Given this list of marker genes NTRK2, GRIN3A, PIK3R2 (phosphoinositide-3-kinase regulatory subunit 2), PRKAG2, GRM1, PRKAB1, TSC2, PIK3CD, GRIN2B, PRKAG1, CAMK4, MAPK1, KRAS (NCBI Gene Id 3845), PIK3R1, PIK3CA, BDNF, GRIN2D, CACNA1C, CAMK2B, DLG4, HRAS, HOMER1, RPTOR, UBE3A, EIF4EBP1, NRAS, RPS6KB1, GRIN1 (NCBI Gene Id 2902), NF1, SHANK3, AKT1, PRKAA1, PIK3CB, TSC1, GRIN2C (NCBI Gene Id 2905), SYNGAP1 (synaptic Ras GTPase activating protein 1), PTEN, AKT3, PRKAA2 (NCBI Gene Id 5563), MTOR, AKT2, ARC, RHEB, PRKAB2, GRIN2A, GRIN3B, PIK3R3, GSK3B, PRKAG3, MAPK3, here is a description of the gene set: Human Gene Set: WP_SYNAPTIC_SIGNALING_ASSOCIATED_WITH_AUTISM_SPECTRUM_DISORDER species: Homo sapiens Synaptic signaling associated with autism spectrum disorder